The following is a description of a gene set: studied in species Mus musculus Any process that results in a change in state or activity of a cell (in terms of movement, secretion, enzyme production, gene expression, etc.) as a result of a calcium ion stimulus. Mouse Gene Set: GOBP_CELLULAR_RESPONSE_TO_CALCIUM_ION, and this is the list of marker genes: Braf, Alox15, Add1, Ncstn, Capn3, Micu1, Smpd1, Cpne7, Alox5ap, Micu2, Cpne4, Cpne3, Adgrv1, Junb, Scn5a, Wnk1, Kcnb1, Slc25a23, Cpne2, Kcnh1, Plcg2, Adcy8, Inhbb, Dpep1, Mcoln1, Wnt5a, Rasgrp2, Lce1d, Neurod2, Nrxn1, Micu3, Itpkc (inositol 1,4,5-trisphosphate 3-kinase C), Gpld1, Cpne9, Adcy1, Akap5, Cpne5, Fosb, Eef2k, Prkaa1, Itpka, Rasa4, Cpne6, Nfatc2, Nfatc3, Akr1c18, Hpca, Mef2a, Abcc9, Slc25a24, Pkd2, Carf, Rasal1, Ryr3, Itpkb, Krt10, Guca1a (NCBI Gene Id 14913), Crhbp, Prkaa2, Kcnq2, Mef2c, Edn1, Syt1, Cpne8, Mylk, Ryr1, Endog, Tuba1a, Crp, Lgmn, Chp2, Nlgn1 (NCBI Gene Id 99949), Jund, Kcnq3, Asph, Fos, Iqgap1, Jun, Ect2, Clic4, Cpne1, Trpm2, Ppif, Fus, Acer1, Nfatc1